Given this list of marker genes YIPF1, B3GALT6, MAN2A1, YIPF2, YIPF6, HID1, GOSR1, ST3GAL1, TMEM59, HLA-A, here is a description of the gene set: species: Homo sapiens Human Gene Set: GOCC_GOLGI_MEDIAL_CISTERNA The middle Golgi cisterna (or cisternae).